The following is a description of a gene set: studied in species Homo sapiens Reactome Pathway: SUMOylation of SUMOylation proteins part of: SUMO E3 ligases SUMOylate target proteins SUMOylation processes themselves can be controlled by SUMOylation. The SUMO E3 ligases PIAS4, RANBP2, and TOPORS are SUMOylated, as is the single SUMO E2 enzyme, UBE2I (UBC9). SUMOylation affects the subcellular location of PIAS4 and TOPORS and affects the activity of PIAS4 and UBE2I., and this is the list of marker genes: NUP160, SUMO2, NUP188, NUP58, NUP210, NDC1, SEH1L, RANBP2, NUP205, NUP107, SEC13, AAAS, UBE2I, NUP54, PIAS4, RAE1, NUP214 (nucleoporin 214), TOPORS, NUP37, SUMO1, NUP153, POM121, NUP62, NUP98, NUP35, NUP43, NUP42, NUP133, NUP93, NUP88, TPR, POM121C, NUP85, NUP155, NUP50